The following is a description of a gene set: Mouse Gene Set: GOBP_FOLIC_ACID_TRANSPORT species: Mus musculus The directed movement of folic acid (pteroylglutamic acid) into, out of or within a cell, or between cells, by means of some agent such as a transporter or pore. Folic acid is widely distributed as a member of the vitamin B complex and is essential for the synthesis of purine and pyrimidines., and this is the list of marker genes: Pdpn (podoplanin), Lrp2, Slc25a32, Slc19a3 (solute carrier family 19, member 3), Folr2, Slc19a1, Abcc5, Folr1 (folate receptor alpha), Slc46a1